The following is a description of a gene set: studied in species Mus musculus from publication Chen Y, Wang X (PMID 31504780) Mouse Gene Set: MIR_3104_5P Genes predicted to be targets of miRBase v22 microRNA mmu_miR_3104_5p in miRDB v6.0 with MirTarget v4 prediction scores > 80 (high confidence targets)., and this is the list of marker genes: Map3k10, Cr2, Dll3, Rpp40, Tmem184b (transmembrane protein 184b), Psd4, Cd3g, Cftr, Arfip2, Fzd7, Pigt, Mecp2, Krtap19-5, Kmt2d, Elf3, Max, Heca, Carhsp1, Akip1, Cd40, Cyp26b1 (cytochrome P450, family 26, subfamily b, polypeptide 1), Pcp4, Pabir2